Given this list of marker genes SLC2A2 (NCBI Gene Id 6514), ALG10, KBTBD8, TMEM198B, CCNYL1, CASP8AP2, TTC14, GCNT3, SNAP25 (NCBI Gene Id 6616), BTBD10, C10orf95-AS1, GUSBP1, PPP1R12A, DNAJC22, TP53INP1, AIDA, MLH3, AGK, PEAK1, NKD2, RNF20, INTS13, SMC1B, CENPH, TARS3, LINC00926, DYNLT3, IFI16, MDGA2, NFU1, CSNK1G1, EAF1, PIK3IP1, NHLRC3, TCTA, CCDC134, DENND11, ZNF146, AGL, RBIS, NBEA, ACBD5, CHST11, ETAA1, ZNF844 (NCBI Gene Id 284391), CTRB2, ZNF347, EEF1E1, BBS2, ZNF85, KBTBD7, PPP3CB, GRAMD1C, C9orf40, LINC00858, LOXL2, AMD1, C1D, PLEKHF2, MIR4453HG, TSPAN6, TAF9B, AP4S1, DHRS1, TNS4, CEMIP2, RLN2 (relaxin 2), HSP90AA1, GORAB, OR11A1, TTLL12, CCDC159, ZBTB44, USP14, CXCL16 (C-X-C motif chemokine ligand 16), TSPYL1 (NCBI Gene Id 7259), ZKSCAN5, UBA3, DNTTIP1, AGAP11, VWDE, CFAP74, YIPF6, VAV3, ZNF616, EIF2B3, LSM3, HGSNAT, IDNK, PINX1, ENSG00000280119, EFHB, GART, SERPINB9, LINC02052, EBF4, CDV3, LACTB2, LNX2, NUDT9P1, TNFRSF10B, NEMP2, HSPH1, GAPDHP62, S100A9, ERLIN2, ZWILCH, KCNH6, TRMT61B, FANCI, CMPK1, SLC30A9, LYRM9, RBMX2, TM2D2, ZNF770, COL21A1, ACTR2, RAB18, ABCG5, ARID4B, HIGD1A, SP3P, GBP2, TMOD4, DENND4C, CDKL3, COL16A1, CEP295, ACTR6, ATXN7, HUS1, GALNT3, ZNF101, ABHD3, DBP, CLN5, RAB3A, HIVEP2, AARSD1, CPT2 (NCBI Gene Id 1376), TRANK1, JADE3, SLC9A9, GPCPD1, ITPKB, MPHOSPH9, MEGF8, MRPL44, SCRN3, DICER1-AS1, CARTPT, CYP2C19, GPR31, CROCCP2, TCEANC2, ZNF829, ALDOC, SLC40A1, GK5, MTR, HNRNPU, FOXM1, NDUFAF6, AKAIN1, ZDHHC6, CR1, NUP58, APOL3, SPART, SUCLG2, INIP, CPM, IMMP2L, GOLGA2P5, TMEM131, SHANK1, PATL2, HTRA3, YIPF5, ZBTB10, EXTL3-AS1, TRIM40, C19orf73, MYL4, HLF, POU1F1, PPP2CB, FAM9C, LINC01792, RSPH4A, ASNSD1, CHI3L2, here is a description of the gene set: Tumor growth is associated with a profound alteration of myelopoiesis, leading to recruitment of immunosuppressive cells known as myeloid-derived suppressor cells (MDSCs). Analyzing the cytokines affecting myelo-monocytic differentiation produced by various experimental tumors, we found that GM-CSF, G-CSF, and IL-6 allowed a rapid generation of MDSCs from precursors present in mouse and human bone marrow (BM). BM-MDSCs induced by GM-CSF+IL-6 possessed the highest tolerogenic activity, as revealed by the ability to impair the priming of IFN- -producing CD8+ T cells upon in vivo adoptive transfer. Moreover, adoptive transfer of syngeneic, GM-CSF+IL-6-conditioned MDSCs to diabetic mice transplanted with allogeneic pancreatic islets resulted in long term acceptance of the allograft and correction of the diabetic status. Cytokines inducing MDSCs acted on a common molecular pathway. Immunoregulatory activity of both tumor-induced and BM-derived MDSCs was entirely dependent on C/EBP transcription factor, a key component of the emergency myelopoiesis triggered by stress and inflammation. Adoptive transfer of tumor antigen-specific CD8+ T lymphocytes resulted in therapy of established tumors only in mice lacking C/EBP in myeloid compartment. These data unveil another link between inflammation and cancer and identify a novel molecular target to control tumor-induced immune suppression. We used gene expression analysis to identify those factors, secreted by tumor-infiltrating MDSC, which could drive emathopoiesis. Moreover we compare gene expression profile of tumor-induced MDSC, obtained from either the spleen and the tumor infiltrate of tumor bearing mice, and in vitro bone marrow-derived MDSC. studied in species Homo sapiens Genes down-regulated in CD11b Tumor from BALBc mouse versus CD11b Tumor from C57BL6 mouse. from publication Marigo I, Bosio E, Solito S, Mesa C, Fernandez A, Dolcetti L, Ugel S, Sonda N, Bicciato S, Falisi E, Calabrese F, Basso G, Zanovello P, Cozzi E, Mandruzzato S, Bronte V (PMID 20605485) Human Gene Set: GSE21927_BALBC_VS_C57BL6_MONOCYTE_TUMOR_DN